The following is a description of a gene set: from publication Chen Y, Wang X (PMID 31504780) Genes predicted to be targets of miRBase v22 microRNA hsa-miR-6858-5p in miRDB v6.0 with MirTarget v4 prediction scores > 80 (high confidence targets). Human Gene Set: MIR6858_5P studied in species Homo sapiens, and this is the list of marker genes: KRT40, CD84, KAT7, ZBTB39, ENDOD1, SCAF4, UBE2QL1, ZNF280D, RTL5, GABRA6, CIT, ATP12A, FNDC3B, PRKRA, GFRA1, ING3, BAZ2A, NRN1, SNPH, UBXN7, SLC25A36, ZDHHC6, LUZP1, ZNF99, MIER1, CCDC178, LEPROT, S1PR1, SLC35F1, ANKUB1, ESYT1, IPO5, FMNL3, SLC34A1, SLAMF7, KIAA1549L, RNASE2, WNT1, VRK3, SEMA7A, GSDMC, EXOC8, TMCO1, SH3TC2, BLMH, CCDC127 (NCBI Gene Id 133957), IGF2R, GRIN2A, VWC2, GPR65, ZNF652, BCAT1, BRPF3, ARHGEF39, FOXJ2, CEP120 (centrosomal protein 120), FAM168A, RACGAP1, FAM167B, GRSF1